Given this list of marker genes AREG, TP63, FGF10, TGM1, EXTL3, CDH3, REG3G, NOTCH2, STXBP4, MIR21, MDK, FGF7, HAS2, LRG1, CRNN, REG3A, here is a description of the gene set: Human Gene Set: GOBP_POSITIVE_REGULATION_OF_KERATINOCYTE_PROLIFERATION species: Homo sapiens Any process that increases the rate, frequency or extent of keratinocyte proliferation. Keratinocyte proliferation is the multiplication or reproduction of keratinocytes, resulting in the expansion of a cell population.